Given this list of marker genes Ttc12, Dnah5, Odad4, Cc2d2a, Spast, Tppp2, Fbxo24, Nckap5l, Odad3, Map1b, Dnah7c, Spag1, Dnai3, Ccdc39, Rsph9, Meig1, Spaca9, Spef2 (NCBI Gene Id 320277), Spag6l, Bbs2, Clxn, Tppp, Trim46, Dnah8, Dcx, Capn6, Tppp3, Dnaaf10 (NCBI Gene Id 216540), Katna1, Numa1, Iqcg, Ift56, Lrguk, Drc1, Armc2 (armadillo repeat containing 2), Togaram1, Rp1, Map7, Odad2, Mapre1, Pierce1, Ofd1, Rsph1, Cep131, Zfp207, Zmynd12 (NCBI Gene Id 332934), Dnaaf5, Dnah17, Gas8, Lrrc23, Psrc1, Ccdc66, Mns1, Spag16, Chp1, Map1s, Ttll13, Foxj1, Mark4, Cfap57, Dnajb13, Trim36, Tpgs1, Dnaaf1 (NCBI Gene Id 68270), Tbc1d21, Fes (feline sarcoma oncogene), Dnaaf2, Cfap43, Ulk4, Cplane2, Cfap97d1, Ak7, Tbc1d32, Ttll5, Cfap73, Mtcl1, Dnaaf4, Lrrc46, Cfap91, Cfap74, Ccdc65, Pdcl2, Pierce2, Cdk5rap2, Neurl1a, Jhy, Map2, Ift88, Plk1, Ttll6, Spef1, Nav1, Hydin, Dnah1, Ccdc40, Dnah2, Odad1, Pla2g3, Tekt2, Dnaaf3, Daw1, Dnah7a, Dnai4, Rsph4a, Ccdc103, Ttll8, Cfap157, Cfap47, Dnaaf6, Drc7, Gas2l1, Ttll1, Stk36, Aaas, Clip1, Dnai2, Cfap69, Clasp1, Ttll3, Ccdc63, Zmynd10, Bbof1, Spag6, Ift46, Gas2l2, Lrrc61, Cfap100, Rp1l1, Fsip1, Prc1, Cfap206, Cfap65, Kif20a, Ccser2, Dnah7b, Dnal1, Spag17, Dnai1, Dnaaf6rt, Rsph6a, Dnaaf11, Ccdc88c, Ube2b, Hoatz, Nckap5, Cfap44, Cfap58, Cluap1, Fsip2, here is a description of the gene set: Mouse Gene Set: GOBP_MICROTUBULE_BUNDLE_FORMATION A process that results in a parallel arrangement of microtubules. studied in species Mus musculus